Given this list of marker genes BLM, TERF1, WRN, SLX1B, SLX4, POT1, TERF2, RECQL4, SLX1A, here is a description of the gene set: Human Gene Set: GOBP_TELOMERIC_D_LOOP_DISASSEMBLY species: Homo sapiens A telomere loop disassembly process that results in the disassembly of telomeric D-loops. A telomeric D-loop is a three-stranded DNA displacement loop that forms at the site where the telomeric 3' single-stranded DNA overhang (formed of the repeat sequence TTAGGG in mammals) is tucked back inside the double-stranded component of telomeric DNA molecule, thus forming a t-loop or telomeric-loop and protecting the chromosome terminus.